The following is a description of a gene set: Human Gene Set: GOBP_POSITIVE_REGULATION_OF_INFLAMMATORY_RESPONSE species: Homo sapiens Any process that activates or increases the frequency, rate or extent of the inflammatory response., and this is the list of marker genes: IDO1, SETD4, NFKBIZ, MAP3K8, GBP3, FFAR3, MGST2, IL33 (NCBI Gene Id 90865), GPSM3, CCR7, ADORA2B (adenosine A2b receptor), IL6, NLRP1, SERPINE1, OSMR, MIR21, IL23A, FCGR1A, S100A9, NLRP6, HYAL2, GRN (NCBI Gene Id 2896), HLA-E, GPRC5B, FFAR2, IL2, VAMP8, NMI, CD81, ETS1, IFNG, MIR142, NEAT1, TRPV4, VAMP7, NAIP, C3, TSLP, IL12B, NLRP12, PARK7, MAPK13, OSM, MIR144, ZDHHC9, LGALS2, SUCNR1, IL1RL1, PDCD4, TLR7, LBP, TRADD, TLR6, LRRK2, MIR181B1, WNT5A, TNIP1, CCL1, DHX9, TNFSF4, TREM2, PYCARD, C2CD4B, CASP1, TNF, RIPK1, IL17RB, TLR2, RPS19, NKG7, BTK, FABP4, CCR2, CASP12, KARS1, MIR206, CTSC, TTBK1, IL16, PTGER3, DEFB114, APP, ADAM8, ZP3, LTA, NINJ1, ABCC1 (NCBI Gene Id 8133), S100A12, LPL, FCER1G, MDK (NCBI Gene Id 4192), ZBP1, PLCG2, TLR3, HTR2A, TLR9, GPR4, DDT, C2CD4A, SNCA, CD47, NLRP3, MIR128-1, TGFB1, CX3CL1, TNFSF18, NAPEPLD, CAMK2N1, STAT5A, AGTR1, CREB3L3, MIR22, IL1B, LILRA5, AGT, TLR4, PTGS2, GBP1, CEBPA, CASP5, MEFV, LGALS1, NUPR1, CLOCK, TAC1, TAFA3, MMP8, PTGER4, ZDHHC5, TNFRSF11A, NFKBIA, CEBPB, STAP1, IL15, TNFRSF1A, PLA2G2A, PLA2G3, NPY5R, CASP4, CCL24, IL21, TNFSF11, CCN4, CD28, IFI35, NLRC4, AIM2, GBP5, FEM1A, MIR126, CASP3, PIK3CG, S100A8, STAT5B, GBP2 (NCBI Gene Id 2634), NLRP10, SNX4, MIR92A1, PLA2G7, IL6ST, CCL3, PDE2A, GSDMD, IL18, LDLR, IL17RA